Given this list of marker genes INS, KCNC2, KDR, ATP2B4, APOE, GUCY1B1, CD36, AGT, THBS1, AGTR2, GUCY1A1, here is a description of the gene set: Human Gene Set: GOBP_NITRIC_OXIDE_CGMP_MEDIATED_SIGNALING An intracellular signaling cassette in which the signal is passed on within the cell by nitric oxide (NO) activating soluble guanylyl cyclase (sGC). Includes synthesis of nitric oxide, guanylyl cyclase activity, and downstream effectors that further transmit the signal within the cell following activation by cGMP. species: Homo sapiens